The following is a description of a gene set: from publication Dienz O, Eaton SM, Bond JP, Neveu W, Moquin D, Noubade R, Briso EM, Charland C, Leonard WJ, Ciliberto G, Teuscher C, Haynes L, Rincon M (PMID 19139170) Genes down-regulated in CD4 T cells: control versus IL6. species: Homo sapiens IL-6, a proinflammtory cytokine produced by antigen presenting cells and non-hematopoietic cells in response to external stimuli, acts as an important bridge between the innate and adaptive immune responses. IL-6 together with IL-4 can promote Th2 polarization, while in combination with TGFbeta mediates Th17 differentiation. We examined early changes in gene expression in mouse CD4+ T cells induced by IL-6. Human Gene Set: GSE7459_UNTREATED_VS_IL6_TREATED_ACT_CD4_TCELL_DN, and this is the list of marker genes: MYO16, PSMB11, LILRB3, PRR3, ZGLP1, ACE2, MLPH, SDC4, GRXCR1 (glutaredoxin and cysteine rich domain containing 1), CXCR2, ARR3, SMAD9, MIR496, AVIL, JAG1, H1-6, VASH2, ACSF3, AMZ1, NRP1, TMEM45A (NCBI Gene Id 55076), SPRED1, MS4A10, PPP1R3C, EGF, PGD, STING1, ADCY8, SLC2A10, ILDR1, SLC30A2, RNF144B, SLC6A15, RTKN, PGAM1, CDRT4, HHEX, SND1, ARHGAP35, UNC5B (NCBI Gene Id 23663), TRO, PGA5, ADORA2B, RBPMS, NAF1, ADAM9, ECM1, RBMY1A1, PBX1, LSM6, NIBAN3, RAP2A, RSPH14, LARGE2, TM4SF5, KRT39, KRTAP19-7, GOLPH3, NR1H5P, CACNG3, ALDH1A2, WDR17, ENTPD1, PGLYRP4, CTNNA1, TMEM41A, GRIA3, KRTAP26-1 (keratin associated protein 26-1), ESM1, CLSTN1, WTIP, MRE11, LTC4S, S100A16, FXYD2, MEP1B, PTH2, FAR2, WNT16, PACRG, ISG20, FAM118B, SYNGAP1, CTDSP2, XRCC3, C1QTNF7, CBLIF, DYNC2LI1, MAP3K9, TRIM72, METTL13, CDH12, GYS2, MT1A, FOXI3, GFAP, NME7, ONECUT2, NEU2, CYFIP1, RASGRF1, PALB2, C1orf54, TMPRSS15, TTC9B, SEMA6D, LRFN3, EFTUD2, PDZK1IP1, NOS1, OLIG2, KANK2, GNA15, PTPN3, CNNM1, MSX1, DIO3, PROCA1, RRS1, GDF6, KREMEN2, GORASP2, SPATS2, H4C3, SHISA9, CPQ, GJA1, HIGD1B, BSX, MAS1, SPATA7, H2AC15, HAND2, TMEM198, COLGALT2, SNAP91, TNMD, MARCHF1 (membrane associated ring-CH-type finger 1), ADAM28, RAD52, DNAJC10, NXPE1, SCN4A, PRDM11, HEPACAM